The following is a description of a gene set: The joining of the lipid bilayer membrane that surround a cell with that of another cell, producing a single cell. studied in species Homo sapiens Human Gene Set: GOBP_PLASMA_MEMBRANE_FUSION, and this is the list of marker genes: MYMX, FREY1, SPESP1, ROPN1B, FOLR3, TMEM95 (transmembrane protein 95), LLCFC1, SPACA3, C16orf92, MYMK, FOLR1, DCST1, TIE1, DCST2, EQTN, SPPL2C, NOX5, NSF, ADAM2, GLIPR1L1, CD9, WDR54, FOLR2, SPACA5, IZUMO1R, SPAM1, LYZL4, SPATA46, TPST2, CRISP1, SPACA6, LYZL6, SPACA5B, SERPINA5, IZUMO1